The following is a description of a gene set: Any process in which a lipid is transported to, or maintained in, a specific location. Human Gene Set: GOBP_LIPID_LOCALIZATION studied in species Homo sapiens, and this is the list of marker genes: TMEM97, CPT2, AKT2, ABCA13, PRELID1 (PRELI domain containing 1), ATG9B, LRP1, SLC25A21, MSR1, ABCC10, TMF1, LDLR (NCBI Gene Id 3949), FABP5, ABCA12 (NCBI Gene Id 3392), SERINC2, GLTP, DRD4, APOM, CRABP1, ABCB4, ABCG8, ABCC2, STARD7, ANO9, PLSCR1, MIR93, CLN8, ITGB3, ATP10D, SPART, NTSR1 (neurotensin receptor 1), LIPG, KCNJ8, TRPC5, OC90, LYPLA1, CIDEC, SLC43A3, CPT1B, TNFSF11, CYP19A1, XKR4, CAV1, SCARB1, PSAP, OSBPL7, APOC4, COMT, OSBPL8, PITPNC1, SHH, SLC22A1, ZDHHC5, APOA1, APOC2, APOO, SERPINA5, SLCO1B3, ANXA1 (NCBI Gene Id 301), TMEM41B, MIR17, SLCO2B1, OXT, KCNQ1, SPNS3, PROCA1, FABP12, LEP, APOF, ABCA4, MIR34A, SLC2A1, XKR9, FURIN, APOL3, ABCC3, PPARA, SLCO1B7, IL1B, ACSL5, PRELID2, ABCA3, CES1, MIR206, VPS13B, PLA2G2D, APOC3, CYP4A11, ARL8B, TMEM135, STARD5, GRAMD1C, PITPNM3, ANO4, VPS13D, INHBA, GALR1, FIS1, SAR1B, VMP1, GPS2, SLC10A4, VPS4B (NCBI Gene Id 9525), DISP3, PRAP1, ARV1, PLIN3, KDM5B, UCP3, GLTPD2, PLA2G2E, OSBP2, TNFRSF11A, PLSCR5, PRELID3B, NOS2, SPX, CRY1, PON1, TEX2, ANO7, CLSTN3, ATP9A, NR0B2, MTTP, PLA2G5, STAR (steroidogenic acute regulatory protein), PLA2G1B, ESYT3, CEACAM1, DENND5B (NCBI Gene Id 160518), SLC25A10, SLC66A2, CRY2, VPS51, PLA2G4F (NCBI Gene Id 255189), FABP1, MIR33B, COMMD1, PPARD, MIR302A, SOAT2, SLCO3A1, KCNN4, ATP8A1, REPIN1 (NCBI Gene Id 96712), IRS2, LPL, AGTR1, PLA2G4A, AVPR1B, SELENOM, SPP1, SLC25A11, P2RX4, STARD3, PRKN, MIR148A, RPS6KB1, TREM2, ESYT2, STARD10, PITPNA, ABCD3, ABCB1, FABP9, PLA2G12B, MIF, GRAMD1A, ERFE, ANXA2, LBP, ACE, ABCD1, MIR128-1, VLDLR, ADIPOQ, SLC27A2, MIR145, RBP5, HDLBP, APOA2, TMEM30A, BLTP3B, OSBPL3, STARD3NL, EHD1, PLA2R1, VPS13C, SCARB2, SLCO1B1, RBP1, ABCG4, YJEFN3, MIR301B, VSTM2A, SLC27A3, ABCA9, TMEM63B, CPT1A, PTGS2, SLCO2A1, LCAT, ATG2A, PITPNB, ATG2B, GOT2, BLTP1, SLC22A11, VPS54, NR1H3, FABP4, STX12, NAXE, OSBPL10, SLC22A24, AKR1C4, FABP3, PITPNM1, NFKB1, RFT1, RELCH, OSBPL1A, SYK, REN, ACSL3, EGF, MFSD2B, SLC27A6, ANO6, MIR26A1, GULP1, SLC51A, THBS1, PLA2G2F, FGF19 (NCBI Gene Id 9965), SEC24A, VAPB, ABCB11, VAPA, ACSL1, TPCN2, SPNS2, NMB, LDLRAP1, APOB, PLA2G12A, FZD4, PTPN2, FABP2, MIR33A (microRNA 33a), TRIAP1, SLCO1A2, PLSCR4, RXRA, TNFAIP8L3, SCP2, ZC3H12A, ATP9B, PLEKHA8P1, SLCO1C1, KCNK9, SLC25A17, AGT, SLC22A7, DAB2, APOL1, MFSD2A (MFSD2 lysolipid transporter A, lysophospholipid), ATG9A, MIR9-1 (NCBI Gene Id 407046), ATP11C, SLC10A6, STOML1, SLCO4A1, MIR19B1, LPA, PNPLA8, LAMTOR1, STRA6, GHRL, DRD3, EEPD1, FASLG, WNK4, EPRS1, IL6, ABCG2, ATP8A2, FABP5P3, VDAC2 (voltage dependent anion channel 2), CFTR, TTC39B, CERT1, POMC, SLC13A3, MIR10B, BMP6 (bone morphogenetic protein 6), CFHR4, SERINC3, ABCA7, ATP10A, CYP4F2, ABCA5, RBP7, FABP7, SLC4A1, ABCG5, APOD, VPS52, SPG11, HILPDA, SERAC1, SGPP1, GRAMD1B, LRP10, APOL4, CROT, ABCA8, ITGAV, ABCA2, GM2A, STOML2, LPCAT3, PLTP, PTGES, MIR144, PTPN11, AKT1 (AKT serine/threonine kinase 1), PDZD8, SLC22A8, CETP, SLC27A1, CRHR1, ABCC4, XKR6, APOL5, VPS4A, XRCC4, PLPPR4, CLPTM1L, SLC25A20, ATP10B, NPC1 (NCBI Gene Id 4864), SOAT1, TNF, EDN1, PTCH1, SERINC5, SFTPA1, PLIN5, PCTP, ATP8B1, FABP6, AKR1C1, SLC10A5 (NCBI Gene Id 369015), ACACB, LRAT, PNPLA2, VPS53, CIDEB, ATP8B4, SLC22A6, MIR613, CPTP, ANO3, TSPO, NKX3-1, PLEKHA8, NUS1, MIR27B, ACSL4, XKR8, APOC1, OSBPL9, OSBPL6, TMEM30B, ATP8B2, PMP2, C2CD2L, APOA5, ABCC11, LYN, SYT7, ABCA1, SLC10A2, ATP11A, MIR185, LIPA, SLC27A5, SIRT1, SLC22A2, NPC2, PLA2G3, MIR758, VDAC1, TTPA, ETNPPL, STARD6, NFKBIA, OSBPL5, DRD2, PLA2G10, NR1H2, PRELID3A, TSPO2, MIR27A, P2RX7, CRH, APOH, SLC10A1, CRP, PPARG, CHKA, RBP2, NMUR2, PLSCR3 (NCBI Gene Id 57048), MIR130B, ABCD2, BDKRB2, PRKCD, CYP7A1, APOLD1, PCSK9, TAC1, ABHD5, VPS13A, ABCC1 (NCBI Gene Id 8133), ATP11B, SLC51B, SLCO1B3-SLCO1B7, APOL6, ABCA6, UCP2, APOBR, OSBPL2, PLA2G2A, C1QTNF1, PLIN2, ECRG4, PLA2G2C, PLSCR2, MIR146A, RBP4, STARD4, RETN, CIDEA, TSKU, OSBPL11, DBI, ABCA10, ESYT1, SLC27A4, ZDHHC8, ABCD4, XKR7, SLC22A9, NPC1L1, CLN3, MYB, C3, SIGMAR1, MIR30C1, CRABP2, PIP4K2A, ATP8B3, SURF4, PITPNM2, NR1H4, GDF9, OSBP, NME4, IKBKE (inhibitor of nuclear factor kappa B kinase subunit epsilon), CLU, ANXA2P2, APOE, CD36, SREBF2, GAL, APOA4, SLC5A8, SLC10A3, SPNS1, ABCG1, MAPK3, LIPC, APOL2